Given this list of marker genes MGP, OXR1, MIR205, MUCL1, CX3CL1, PROM1, FOSB, TAGLN, CSNK1A1, NFIB, ELF5, ELF3, ZNF204P, PI15, ZBTB16, RHOQ, PSMA3-AS1, SYNM (NCBI Gene Id 23336), RPL31, ATF3, CAV1, HYCC1, PTN, SFRP1, MAOA, FYB2, ECRG4 (NCBI Gene Id 84417), ATP1A2, CNN1, MYH11, ID4, PIGR, CRYAB, MAMDC2, CYB5R2, GABRP, FOS, CRISPLD1, CFD, PDZK1, CARMN, ACTA2, SAA1, KRT14, TMEM150C, MYLK, SCGB2A2, IQCN, YBX3, GPM6B, IGHA1, PAK3, SORBS1, IQCA1, ZNF154, BACH2, MMP7, ZNF573, ROPN1, ACTG2, SENP6, ATP10D, ADH1B, PLEKHS1, GHR, KRT17, KRT5, NTRK2, ANXA1, AK5, RCAN1, CADM1 (NCBI Gene Id 337934), SYNPO2, here is a description of the gene set: Genes down-regulated in ductal carcinoma vs normal lobular breast cells. studied in species Homo sapiens BACKGROUND: Invasive ductal and lobular carcinomas (IDC and ILC) are the most common histological types of breast cancer. Clinical follow-up data and metastatic patterns suggest that the development and progression of these tumors are different. The aim of our study was to identify gene expression profiles of IDC and ILC in relation to normal breast epithelial cells. METHODS: We examined 30 samples (normal ductal and lobular cells from 10 patients, IDC cells from 5 patients, ILC cells from 5 patients) microdissected from cryosections of ten mastectomy specimens from postmenopausal patients. Fifty nanograms of total RNA were amplified and labeled by PCR and in vitro transcription. Samples were analysed upon Affymetrix U133 Plus 2.0 Arrays. The expression of seven differentially expressed genes (CDH1, EMP1, DDR1, DVL1, KRT5, KRT6, KRT17) was verified by immunohistochemistry on tissue microarrays. Expression of ASPN mRNA was validated by in situ hybridization on frozen sections, and CTHRC1, ASPN and COL3A1 were tested by PCR. RESULTS: Using GCOS pairwise comparison algorithm and rank products we have identified 84 named genes common to ILC versus normal cell types, 74 named genes common to IDC versus normal cell types, 78 named genes differentially expressed between normal ductal and lobular cells, and 28 named genes between IDC and ILC. Genes distinguishing between IDC and ILC are involved in epithelial-mesenchymal transition, TGF-beta and Wnt signaling. These changes were present in both tumor types but appeared to be more prominent in ILC. Immunohistochemistry for several novel markers (EMP1, DVL1, DDR1) distinguished large sets of IDC from ILC. CONCLUSION: IDC and ILC can be differentiated both at the gene and protein levels. In this study we report two candidate genes, asporin (ASPN) and collagen triple helix repeat containing 1 (CTHRC1) which might be significant in breast carcinogenesis. Besides E-cadherin, the proteins validated on tissue microarrays (EMP1, DVL1, DDR1) may represent novel immunohistochemical markers helpful in distinguishing between IDC and ILC. Further studies with larger sets of patients are needed to verify the gene expression profiles of various histological types of breast cancer in order to determine molecular subclassifications, prognosis and the optimum treatment strategies. Human Gene Set: TURASHVILI_BREAST_DUCTAL_CARCINOMA_VS_LOBULAR_NORMAL_DN from publication Turashvili G, Bouchal J, Baumforth K, Wei W, Dziechciarkova M, Ehrmann J, Klein J, Fridman E, Skarda J, Srovnal J, Hajduch M, Murray P, Kolar Z (PMID 17389037)